The following is a description of a gene set: species: Mus musculus Mouse Gene Set: chr5E3, and this is the list of marker genes: Gm43225, Pramel46, Cfap299, Gm42759, Pramel47, Cxcl13, Mrpl1, Cnot6l, Gm8048, Gm3176, Gm6468, Gm33370, Gm7919, Pramel41, Gm33969, Pramel43, Gm7663, Anxa3, Pramel57, Gm5560, Bmp3, Gm7647, BC080696, Gm9484, Gm3302, Gm24623, Gm7993, Pramel58, Gm2840, Gm8041, Pramel36, Gm33609, 4930467D21Rik, Gm5559, Pramel54, 1700016F12Rik, Pramel48, Gk2, Pramel59, Gm6346, Gm3470, Naa11, Pramel45, Pramel53, A730035I17Rik, Gm3089, Pramel37, Mir703, Pramel38, Fras1, Prkg2, Pramel49, Fgf5, Pramel42, Gm33050, Pramel40, Pramel55, Pramel35, Gm7939, Gm7961, Gm24279, Pramel44, Pramel52-ps, Antxr2 (NCBI Gene Id 79402), Pramel50, C430019N01Rik, Pramel56, Paqr3, Gm8013, Gm32072, Prdm8, Bmp2k, 1700010H22Rik, Pramel39-ps, E030032P16Rik, Gm35394, Pramel60, Gm6348